The following is a description of a gene set: Mouse Gene Set: GOBP_RESPONSE_TO_MUSCLE_ACTIVITY species: Mus musculus Any process that results in a change in state or activity of a cell or an organism (in terms of movement, secretion, enzyme production, gene expression, etc.) as a result of a muscle activity stimulus., and this is the list of marker genes: Lncbate10, Mstn, Metrnl (meteorin, glial cell differentiation regulator-like), Myog, Mir680-1, Ryr2, Mir709, Mir680-3, Prkag3, Postn, Selenon, Myh2, Itga2, Itga5, Slc38a2, Adsl, Srl, Perm1, Agt, Mir680-2, Capn3, Atp5f1a (ATP synthase F1 subunit alpha), Prkaa2, Myh4, Ppargc1a, Dag1, Slc7a5, Mtfp1, Abcg8, Myhas, Hif1a, Col6a1, Fn1, Mir21a, Itgb1, Tns2, Fndc5, Mir762, Mir705 (NCBI Gene Id 735267, microRNA 705), Tomm20, Abcg5